Given this list of marker genes RAF1, NDN, CD2AP, CASP3 (NCBI Gene Id 836), DOK5, DOCK3, WASF1, AKT1S1, SPRY2, DDIT4, BCAR1, CYFIP1, SORT1 (sortilin 1), ZDHHC17, AGT, PTPN11, PPP2R5B, ZFYVE27, NGF, AGTR2, TMEM108, NTRK1, HAP1, CYFIP2 (NCBI Gene Id 81032), SOS1, SPRY1, here is a description of the gene set: The series of molecular signals initiated by neurotrophin binding to its receptor on the surface of a target cell where the receptor possesses tyrosine kinase activity, and ending with the regulation of a downstream cellular process, e.g. transcription. species: Homo sapiens Human Gene Set: GOBP_NEUROTROPHIN_TRK_RECEPTOR_SIGNALING_PATHWAY